Given this list of marker genes CD9 (NCBI Gene Id 928), CD81, PTGFRN, MYMX, MYMK, here is a description of the gene set: A process in which non-proliferating myoblasts, after migrating to the site of injury, fuse into existing damaged fibers or fuse to myotubes to form new fibers, as part of the process of skeletal muscle regeneration. A myoblast is a mononucleate cell type that, by fusion with other myoblasts, gives rise to the myotubes that eventually develop into skeletal muscle fibers. studied in species Homo sapiens Human Gene Set: GOBP_MYOBLAST_FUSION_INVOLVED_IN_SKELETAL_MUSCLE_REGENERATION